Given this list of marker genes PAQR7, AKT2, PIK3CB, AKT1, PIK3CD, AKT3, PIK3CA, PAQR8, PAQR5, here is a description of the gene set: Pathway Definition from KEGG: P4 -> mPR -> PI3K -> PIP3 -> AKT Human Gene Set: KEGG_MEDICUS_REFERENCE_MEMBRANE_INITIATED_PROGESTERONE_SIGNALING_PATHWAY species: Homo sapiens Membrane-initiated progesterone signaling pathway. Pathway ID: N01356. Pathway type: Reference. Pathway class: nt06214 PI3K signaling.